The following is a description of a gene set: studied in species Homo sapiens Human Gene Set: GOBP_NEGATIVE_REGULATION_OF_TRANSPORT Any process that stops, prevents, or reduces the frequency, rate or extent of the directed movement of substances (such as macromolecules, small molecules, ions) into, out of or within a cell, or between cells, by means of some agent such as a transporter or pore., and this is the list of marker genes: ARF6, UCN, GPR35, NEU3, WDR41, APPL1, MIR200C, APOC3, STXBP3, NR1H2, MIR758, PID1, LYPLAL1, NMU, CD47, LEP, CHGA, RGS2, NRG1, CTTNBP2NL, VAMP8, NPVF, HTR2A, SHH, GJA1, F2R, NOS1, SVIP, PACSIN1, MIR92B, VPS35, MIR24-1, OAZ2, CLDN3, PLA2R1, ATG3, MIR144, FRMD4A, MIR107, PKIG (cAMP-dependent protein kinase inhibitor gamma), ENY2, CORO1A, ISCU, AKT1, NEO1, PTPN11, UBE2G2, DYSF, GNAI1, NTSR1, WNK3, MCUB, OSR1, SNX12, CYP4F2 (cytochrome P450 family 4 subfamily F member 2), FIS1, OPRK1 (NCBI Gene Id 4986), PRKCB, LILRB1, CRY1 (NCBI Gene Id 1407), MIR212, CD300A, INHBA, YRDC, MTMR4, SNX3, MIR495, ADIPOQ, CD84, ARHGAP8, TGFB1, DDX39A, IRS2, CAV1 (caveolin 1), INSIG1, CCR2, KCNJ11, PKIA, RAB11FIP1, YWHAQ, APOA2, MIR19B1, VAMP3, FMR1, ARL6IP5, CERS1, CRHBP, CNN2, VSNL1, VPS4B, MIR1-1, LIF, EDN1, RANGAP1, ANK3, RIN3, BCR, PFKL, FAM3D, MIR33B, FOXF1, REM1, SCAMP5, GABBR1, STXBP6, MIR208B, TSPO, LRPAP1, EPO, BARD1, CRYAA, F2RL1 (F2R like trypsin receptor 1), UBQLN2 (ubiquilin 2, NCBI Gene Id 29978), CRY2, SLC43A2, KLF7, PPP3CA, FKBP1B, APPL2, CAB39, FERMT1, P2RY1, UBAC2, FOXO1, CBARP, GOPC, KCNRG, ADTRP (NCBI Gene Id 84830), APOC1, SLC43A1, SYT4, RABGEF1, PIP4P2 (phosphatidylinositol-4,5-bisphosphate 4-phosphatase 2), EPPIN, MIR451A, WNK4, NECAB2, DRD2, PRKG2, CTNND1, ANKRD13D, IL13RA2, ATF4, OSM (NCBI Gene Id 5008), MIR185, GNAI2, KEL, TLR2, PTEN (phosphatase and tensin homolog), HDAC3, MIR145, ARFIP1, OAZ3, MCTP1, PPP3CC (NCBI Gene Id 5533), IRS1, PICALM, MIR143, MRLN, CRH, B2M, MIR205, NUP153, MMP9, NEUROG1, CALM1, ERP29, OAZ1, ABAT, CD74, YWHAE, APOC2, IL1RAPL1, INHBB, TRAT1, UBR3, DRD4, TLR9, RAB23, RAC1, MIR30C1, RHBDF2 (NCBI Gene Id 79651), MTNR1B, ATXN2 (ataxin 2), EGF, SIRT6, TNFRSF1B, CALCA, TFF2 (trefoil factor 2), SELENOS, RSAD2, GNB5, PTK2B, SERGEF, MAPK3, MIR326, SH3GL3, MIR27B, OPRM1, HMGCR, MAP1B, THBS1 (thrombospondin 1), LILRB2, FCGR2B, IL1B, SDCBP, TIFAB, RAP1BL, CALM3, RAB11FIP3, MIR129-1, NOS3, PPIF, ABCA2, ATP9A, FGF23, LYPLA1, SERPINE2, UBE2J1, KCNE2, PRTN3, NPY5R, SLC30A1, STX1B, PPP3R1, BCL2, KCNE5, SYT11, OSTN, ADRA2B, KCNB1, PIM3, RUBCN, NOTCH1, MIR186, PRKD1, CD36, ENPP1, ITGB3, GRB10, NDFIP1, BMP8A, MIR103A1, STC1, UNC119, OS9, CABP1, MIR30D, NDFIP2, NMB, GABRE, TBC1D4, MDFIC, ANXA1, GNAO1, PLSCR1, SCT (secretin), PRRT2, PNKD, YWHAB, RAB33B, KCNK9, CARTPT (CART prepropeptide), TCAF2, CD300LF, RAB7A, ASIC1, EI24, UBQLN1, MIR130B, MIR34B, DCANP1, YOD1, GNAZ, FABP5, RACK1, PLA2G10, PSMD9, APOD, ACSL4, MIR34A, ADA, ANKRD27, RSC1A1, HAMP, PTGER3, LGALS3, ERLEC1, UFM1, CHP1, SLN, MIR208A, SUMO1, PACSIN3, AGT, CEACAM1, PPM1F, PRKCE, SPX, INS, MIR613, HMGB1, PRKN, MIR301B, ABCA7, LRRTM2, SUFU, SFRP4, ERBB3, MIR148A, RHBDF1, CD200, INPP5K, MIR9-1, COMMD1, TXN, SMCR8, FFAR4, SNCA, SREBF1, APOE, OXSR1, PKDCC, IDH2, ANGPT1, TRH, RBM10, PDE8B, RAP1B, CSK, ABCC8, KCNH2, DERL3, LGALS9, MTMR2, RAP1A, FAM76B, NF1, MIR206, MIR17, MIR499A, GHSR, NR1H3, ACTN2, RAB11FIP5, ATP1A2, C9orf72, PPP3R2, MIR93, ADRA2C, PLN, TPR, PRKG1, GHRL, PEA15, MIR181B1, UCP2, MIR146A, MIDN, PARK7, MIR199A1, ANXA13, LRSAM1, PACSIN2, DERL2, ANXA2, CYP51A1, REST, SP100, NCKAP1L, IL12A, MIR508, PPP3CB, PCSK9, MIR26A1, NEDD4, LRRK2, JAGN1, ANKRD13B, CRYAB, GRP, NFKBIA, LRRTM1, AKT2 (NCBI Gene Id 208), TNF, STK39, ADRA2A, NEDD4L, SESTD1, GRM7, KCNE1 (potassium voltage-gated channel subfamily E regulatory subunit 1), SPI1, SREBF2, DLG4, EPHA3, IL11, MIR27A, SIRT4, CASQ2, WWP2, SLC26A5, MIR33A, WDR54, MIR133A1, MIR302A, WNK1, GGCX, CALM2, BRAF, KCNE3, MIR766, MIR448, MIR128-1, RGS4 (NCBI Gene Id 5999), SEMG1, PXK, MIR133B, CAMK2D, CAV3, HES1, CCN3, CACNA1F, NPSR1, NPFF, GPM6B, VDAC1, TRIM27, HTR1B, TNFRSF1A, ITGAV, CRBN, DPH3, NDUFAF2, ADORA1, GSK3A, TMBIM6, NPY2R, ARHGAP1, ACVR1C, MIR29B1, SNX33, MIR873, ATG5, HADH, KCNQ1, MIR424, GSTO1, MIR328, SIRPA, NHERF1, FFAR2, SPINK1, INHA, HLA-F, DRD3, TACR2, BEST3, BIN1, SYTL4, CRHR1 (NCBI Gene Id 1394), MIR192, MIR19A, HCRT, CDK5, KCNAB1, PROM2, ANKRD13A, IL12B